The following is a description of a gene set: studied in species Homo sapiens Human Gene Set: HP_MISCARRIAGE A pregnancy that ends at a stage in which the fetus is incapable of surviving on its own, defined as the spontaneous loss of a fetus before the 22th week of pregnancy. Miscarriage, and this is the list of marker genes: HOXA13, MGP, HSPG2, FCGR3B, PLXND1, NLRP7, FGB, RHCE, DLK1, SERPINC1, MYF6, RHAG, DNM2, FGA, MPL, MTMR14, RHD, FGG, JAK2, REC114 (NCBI Gene Id 283677), NSD2, PLIN1, ALB, HBB, RTL1, BIN1, ENG, SERPINE1, CLN8, RYR1, WRN, MEG3, RAD51C, THPO